Given this list of marker genes SSC5D, TLR6, SCARB1, C4B, LBP, TLR1, TLR4, TLR9, NOD2, LY96, TLR2, NR4A1, TREM2, here is a description of the gene set: The series of events in which a stimulus from a molecule of bacterial origin is received and converted into a molecular signal. studied in species Homo sapiens Human Gene Set: GOBP_DETECTION_OF_MOLECULE_OF_BACTERIAL_ORIGIN